The following is a description of a gene set: studied in species Mus musculus Mouse Gene Set: GOBP_NORADRENERGIC_NEURON_DIFFERENTIATION The process in which a relatively unspecialized cell acquires specialized features of an noradrenergic neuron, a neuron that secretes noradrenaline., and this is the list of marker genes: Edn1 (NCBI Gene Id 13614), Ascl1, Insm1, Sox4, Rnf220, Phox2b, Zc4h2, Sox11, Ednra, Phox2a